Given this list of marker genes Slc2a6, Creg1, Grn, Camk1d, Klf6, Jun, Tsc22d3, Ccl9, Eef2, Ptpn22, Klf4, Mcemp1, Ppp1r15a, Sult1a1, Pdcd4, Junb, Iqgap2, Tnfsf9, Hspa1a, Aph1c, Nr4a2, Sh3kbp1, Sgk1, Klhl24, Smpdl3a, Itgb7, Npc2, Ptpn18, Ccr2, Zeb2, Mbnl1, Trps1, Hexa, Pid1, Fos, C3, Dusp1, Pla2g7 (phospholipase A2, group VII (platelet-activating factor acetylhydrolase, plasma)), Lmo4, Zbtb20, Adgre4, Ypel3, Itm2b, Alox5ap, Ms4a6c, Ap1s2, St8sia6, Sowahc, Eif3f, Stap1, Rhob (ras homolog family member B), Zfp36, Hspa1b, Egr1, Il1b, Psap, Mink1, Lyz2, Hsd17b11, Zfp36l1, Cd180, Abca1, Erp29, Ccnl1, Ctss, Lyst, Btg2, Mpeg1, Ccrl2, Ptprc, Arl5c, Cox7a2l, Prcp, Ubc, Adgre1, Nfkbia, Klf2, Cx3cr1, Igbp1, Sorl1, Tmem50a, Niban1, Nfkbiz, Abca9, Cd81, Arhgap15, Smap2, Stom, Cd33, Neat1, Fosb, Atf3, Ifngr1, Ramp1 (NCBI Gene Id 77677), Fuca1, Emb, Higd2a, Nsa2, Per1, Cd47 (CD47 antigen (Rh-related antigen, integrin-associated signal transducer)), Bnip3l, Foxp1, Selenop, Ccl6, Ier2, Tent5a, Cybb (NCBI Gene Id 97621), Eif3e, Ctsc, H2-K1, Jund, Hexb, Nr4a1, Tmcc1, Bri3 (brain protein I3), Rnf130, Tyrobp (TYRO protein tyrosine kinase binding protein), here is a description of the gene set: Genes negatively differentially expressed in cell type: cDC2 (conventional dendritic cell type 2) upon treatment with cytokine: IL-3 in mouse lymph nodes in vivo. Mouse Gene Set: CUI_CDC2_IL3_RESPONSE_DN Cytokines mediate cell-cell communication in the immune system and represent important therapeutic targets. A myriad of studies have highlighted their central role in immune function, yet we lack a global view of the cellular responses of each immune cell type to each cytokine. To address this gap, the authors created the Immune Dictionary, a compendium of single-cell transcriptomic profiles of more than 17 immune cell types in response to each of 86 cytokines (>1,400 cytokine-cell type combinations) in mouse lymph nodes in vivo. A cytokine-centric view of the dictionary revealed that most cytokines induce highly cell-type-specific responses. For example, the inflammatory cytokine interleukin-1β induces distinct gene programmes in almost every cell type. A cell-type-centric view of the dictionary identified more than 66 cytokine-driven cellular polarization states across immune cell types, including previously uncharacterized states such as an interleukin-18-induced polyfunctional natural killer cell state. from publication Cui A, Huang T, Li S, Ma A, Pérez JL, Sander C, Keskin DB, Wu CJ, Fraenkel E, Hacohen N (PMID 38057668) species: Mus musculus